Given this list of marker genes Spi1 (Spi-1 proto-oncogene), Tradd, Tnfrsf22, Atf3, Tnfrsf10b, Fadd, Park7, Casp8, Zdhhc3, Tnfsf10, here is a description of the gene set: species: Mus musculus An extrinsic apoptotic signaling pathway initiated by the binding of the ligand TRAIL (tumor necrosis factor-related apoptosis-inducing ligand) to a death receptor on the cell surface. Mouse Gene Set: GOBP_TRAIL_ACTIVATED_APOPTOTIC_SIGNALING_PATHWAY